The following is a description of a gene set: The NuMA protein, which functions as a nuclear matrix protein in interphase, redistributes to the cytoplasm following nuclear envelope breakdown where it plays an essential role in formation and maintenance of the spindle poles (Gaglio, et al., 1995; Gaglio, et al., 1996; Merdes et al, 1996). The mitotic activation of NuMA involves Ran-GTP-dependent dissociation from importin. NuMA is transported to the mitotic poles where it forms an insoluble crescent around centrosomes tethering microtubules into the bipolar configuration of the mitotic apparatus. Although NuMA is not a bona fide constituent of the mitotic centrosome but rather a protein associated with microtubules at the spindle pole, specific splice variants of NuMA have been identified that associate with the centrosome during interphase. species: Homo sapiens Reactome Pathway: Recruitment of NuMA to mitotic centrosomes part of: Mitotic Prometaphase, and this is the list of marker genes: HAUS3, CEP164, MAPRE1, TUBGCP3, CPAP, ACTR1A, PCM1, MZT1, CEP290, ALMS1, SDCCAG8, HAUS5, CDK1, CCP110, PRKAR2B, TUBA1A, NUMA1, TUBA4B, TUBB6, TUBA1C, CEP72, PPP2R1A, HAUS6, PRKACA, TUBGCP5, SFI1, TUBA1B, TUBB2A, PLK4, TUBA3E, TUBA8, TUBGCP4, CSNK1E, OFD1, CDK5RAP2, CSNK1D, ODF2, TUBB8B, CETN2, TUBB8 (tubulin beta 8 class VIII), TUBB3, TUBA3D (NCBI Gene Id 150778), TUBA3C, TUBGCP2, CEP76, CEP57, TUBGCP6, CLASP1, NEDD1, CEP152, PAFAH1B1, TUBA4A, NEK2, NME7, TUBB1, MZT2B, CEP192, HAUS1, MZT2A, TUBG2, CEP250, DCTN1, HAUS7, CEP131, HAUS2, CKAP5, CEP70, CEP78, TUBAL3, TUBB4A, TUBB2B, DYNC1H1, YWHAG, CEP41, CEP63, DYNLL1, CEP43, NDE1, HAUS4, PCNT, PLK1, TUBG1, HSP90AA1, DCTN2, CEP135, SSNA1 (SS nuclear autoantigen 1), NINL, DCTN3, YWHAE, TUBB4B, HAUS8, CNTRL (NCBI Gene Id 11064), AKAP9, TUBB, DYNC1I2